Given this list of marker genes Vmp1, Drd1, Cxcl10, Wnk1, Ppp3r2, Gjc2, Reln, Atpsckmt, Pkd2, Plcg1, Gal, Cacnb2, Sri, Kcne5, Ntsr1, Ednra, P2rx7, Trpc3, Slc9a1, Snca, Nipsnap2, Gsto1, Ndufa4, Xcl1, Cxcl11, G6pdx, Ffar1, Bmp4, Capn3, Oprk1, Grm6 (NCBI Gene Id 216727), Plcg2, Cacnb3, Fgf13, Agtr1a, Akap9, Hap1, Stimate, Atp7a, Ikbkb, Aplnr, Adrb1, Stac2, Trdn, Tesc, Plp1, Atp1b3, Nherf2, Kcnc2 (potassium voltage gated channel, Shaw-related subfamily, member 2), P2rx5, P2ry6, Il13, Cd19, Lhcgr, Clec4b1, Drd4, Fxyd7, Stim2, Scn1b, F2, Arf1, Rgs7, Cnksr3, Bax (NCBI Gene Id 12028), Actn2, Gimap5, Gimap3, F2rl3, Gpr39, Wnk2, Ano6, Cemip, Wnk3, Ehd3, Nos1, Dmd, G6pd2, Lcn2, Kcnh2, Kcne1, Akap6, Plcb1, Tcaf1 (TRPM8 channel-associated factor 1), Fxyd3, Lrrc55, Cftr, Dbi, Cxcl9, Bdkrb1, Htt, Grin1, Lrrc38, Nedd4l, Rnf207, Bak1, Heph, Lrrc52, Rapgef3, Ppp3r1, Tescl (NCBI Gene Id 69301), Kcnip2, Hspa2, Calm2, Trpc1, Gstm7, Prss8, Abl1, Cacna1d, Abcb1a, Flna, Edn3, Nherf1, F2r, Pirt, Atp1b1, Trpc6, Cav1, Fxyd4, Npsr1, P2rx4, Fxyd5, Ppp3cb, Calm1, Kcnc1, Fxyd1 (NCBI Gene Id 80524), Asph, Kcnq1 (NCBI Gene Id 547397), Strit1, Edn1, Amigo1, Stim1, Cox17, Wnk4, Fgf14, Lrrc26, Coa8, Stac3, Gper1, Jph2, Atp2a1, Cx3cl1, Stac, Adcyap1r1, Nlgn3, Fxyd2, Cacna1c, Ctss (cathepsin S), Adrb2, Cd4, Atp1b2 (NCBI Gene Id 11932), Kcnmb1, Cracr2a, Fxyd6, Ppp3ca, Casq1, Ank2, Sumo1, Galr2, Kcnj2, Dpp6, Akap7, Ank3, Thy1, Ifng, P2rx1, Oga, Ppp3cc, Calm3, Abcb1b, Chp1, Ms4a1, Akap5, Pdpk1, Nppa, Cxcr3, here is a description of the gene set: studied in species Mus musculus Any process that activates or increases the frequency, rate or extent of the directed movement of ions from one side of a membrane to the other. Mouse Gene Set: GOBP_POSITIVE_REGULATION_OF_MONOATOMIC_ION_TRANSMEMBRANE_TRANSPORT